The following is a description of a gene set: Table S2: Representative genes of each cell cluster studied in species Mus musculus Mouse Gene Set: ZHANG_UTERUS_C2_SECRETORY_STROMAL3_RAMP3_HIGH_CELL from publication Zhang L, Long W, Xu W, Chen X, Zhao X, Wu B (PMID 35669188), and this is the list of marker genes: Dnajb1, Rpl36a-ps2, Ackr3, Ubc, Rps10-ps2, Gm14165, Mxra8, Plk2, Gja1, Rpl10, Cd164 (NCBI Gene Id 53599), Lox, Anxa2, S100a16, Sgk1, Vapa, Fbln2, Wipi1, Vim, Cdh11, Crispld2, Sec61a1, Ssr3, Rpl10a-ps1, Nme2, Sptssa, Fn1, Fos, Rhob, Rps18-ps5, Myl6, mt-Nd3, Trabd2b, Rpl15, Des, Gm10177, Tnfrsf12a, Yipf5, Fosb, Serpinf1, Gm12174, Spon2, Sar1a, Btg1, Pdia6, Col3a1, Kdelr3, Fbn1, Cryab (NCBI Gene Id 12955), Rcn3, Sec61g, Fstl1, Pttg1ip, Gm12481, Tmt1a, Herpud1, Sec61b, Myl12a, Gng12, Rab6a, Tmem109, Map1lc3a, Rps3a2, Dio2, A2m, Rps15a-ps6, Gm13588, Ost4, Col6a1, Tmem258, Hspa1b, Cyb5a, Morf4l2, Rps13-ps2, Rps6-ps4, Vkorc1, Meg3, Ccl11, Swi5 (SWI5 recombination repair homolog (yeast)), Rasd1, Loxl2, Rpl18-ps1, Rpl14-ps1 (ribosomal protein L14, pseudogene 1), Rpl6l, Rps27rt, Cd81, Col6a4, Cope, Gm15427, Sdk1, Gm10073, Pdia3 (protein disulfide isomerase associated 3), Serpine1, Ggt5, Pnp, Pgrmc1, Msrb2 (NCBI Gene Id 76467), Rps26-ps1, Scube1, Mir703, Col6a3, Arf4 (ADP-ribosylation factor 4), Gm7600, Gm9794, Rpl3-ps1, Sdc1, Selenof, Klf4, Tmsb10, Cstb, Dbi, Dusp1, Gm11478, Adprh, Scd2, Gm5905 (NCBI Gene Id 640115), Ubb-ps, Gm14303, Aldoa, Gm5586, Tuba1a, Igfbp5, Gm4366, Ddit4l, Aldh1a2, Gm15500, Axl, Tceal8, Igf1, Ssr4, Uba52, Gas5, Ier2 (immediate early response 2), Anxa5, Serf2, Rpl34-ps1, Gm9843, Wnt5a, Inhbb, Ogn, Col5a1, Htra1, Gm10288, Gm5805, Rpl9-ps6 (NCBI Gene Id 100048162), 2310022B05Rik, Srm, Ckap4, Igfbp6, Ramp2, Ngfr, Col15a1, Wdr89, Cald1, Lgals1, Rpl4, Rhoc (ras homolog family member C), Ramp3, Klf6, Lrp1, Gm4149, Tpm4, Laptm4a, Snhg18, Gm10736 (NCBI Gene Id 100504654), Rcn1, Anxa3, Gm8797, Ltbp4, Rps6, Gpx8, Raly, P2ry14, Eln, Tmem119, Rrbp1, Sparc, Uba52rt, Tppp3, Gm8730, Dap, Tmed2, Tnfaip6, Col5a2, Surf4, Anxa1, Gm15772, Gm3511, Nedd4, Eif4a2, Ebf1, Rpl35rt, Spon1, Ift20, Col6a2, Ckb, Ftl1-ps1, Gm6863, Atp8a1, Ilk, Rps18, Gm5835, Rpl39-ps, Hspa5, Mfap5, Ech1, Arl4c, Hspa1a, Gm7536, Cd248, Mmp23, Gm13436, Rpl10-ps3, Gm6204, Tcf4, Gm10076, Maged2, Ccn1, Maged1, Prkar1a, Rps25-ps1, Ppic, Rpl35, Hdlbp, Ppib, Slc25a39, Rps23-ps1, Rpl28-ps1, Gm9385, Tubb2a, Gadd45g, Tubb6, Gm6136, Ddost, Col1a2, Cavin3, Dstn, Gsn, Tmed3, Oxtr, Emb, mt-Nd5, Mmp19, mt-Co1, Plod2, Gas6, Prss23, Cd34, Selenos, Cd63-ps, Eef1a1, Tpt1-ps3, Atp6v0d1, Eef1g, Jun, Rps19-ps6, Col1a1, Calu, Ccl7, Gpx4, Gm14586, Gstp1, Kdelr2, Bst2, Hsd11b2, Errfi1, Ppp1r15a, Dcn, Mfge8, Nppc, Spcs1, Rps15a-ps7, Gm7808, P4hb, Gapdh, Rpl37rt, Rpl31-ps8, Rplp0, Serpinh1, Egr1